Given this list of marker genes Kcnh2, Cacnb3, Scn2b, Kcnj8, Kcnj5, Kcne4, Kcne3, Cav1, Cacna2d1, Kcne2, Kcnj2, Kcne5, Kcna1, Flna, Dlg1 (discs large MAGUK scaffold protein 1), Kcna5, Kcnn2, Kcne1, Rnf207, Kcnd3, Kcnq1, Kcnh6, here is a description of the gene set: The process in which ions are transported across a membrane such that the membrane potential changes in the direction from the positive membrane potential at the peak of the action potential towards the negative resting potential. species: Mus musculus Mouse Gene Set: GOBP_MEMBRANE_REPOLARIZATION_DURING_ACTION_POTENTIAL